The following is a description of a gene set: Human Gene Set: GNF2_PCNA Neighborhood of PCNA proliferating cell nuclear antigen in the GNF2 expression compendium species: Homo sapiens Neighborhood of PCNA, and this is the list of marker genes: BUB1B, RRM1, PRC1, RRM2 (NCBI Gene Id 6241), GINS1, KIF18B, CENPF, MT1JP, MKI67, FANCI, DNAJC9, MCM2, KIF15, SHCBP1, CCNB2, ZWINT, MCM7, DLGAP5 (NCBI Gene Id 9787), RACGAP1, CDC20, CCNA2, MCM3, ASPM, PRIM1, TYMS, CENPE, H2AX, DTL, HMMR, PCNA, BIRC5, TMPO, TOP2A, MELK, SMC2, MCM4, VRK1, RAD54L, NUSAP1, HNRNPAB (NCBI Gene Id 3182), POLE2, MCM6, SLBP, KIF11, PCLAF, MYBL2, CDK1, MSH2, FEN1, TPX2, GINS2, AURKA, NSD2, RFC4, CDCA8, NDC80, MCM5 (NCBI Gene Id 4174), CKS2, ESPL1 (NCBI Gene Id 9700), RAD51AP1, FOXM1, TTK, PAXIP1, GMNN, PA2G4, SMC4, PLK4, HMGB2